Given this list of marker genes ADARB1, PIP4K2C, POMT2, ABAT, HLA-G, RASSF2, MAP2K1, APMAP, JAK1, RAB8B, TENM1, SPTBN1, TMEM248, ANGPTL2, NCALD, TNFRSF25, OMG, EPAS1, SGK1, HTR2B, ADAM23, RAC2, ID3, COTL1, EGR1, CD6, EHD4 (EH domain containing 4), DCLRE1A, CRTAM, HCP5, PLA2G4C, INPP5B, STAT1, IFITM1, IL6R, HGF (NCBI Gene Id 317720), DHRS3, GBP2 (NCBI Gene Id 2634), PDCD4, LPIN2, ICOS, TNF, PTCH1, KLF10, SATB2, RBM38, BACH2, IER2, ZFP36L1, HDAC5, DCHS1, NR4A3 (nuclear receptor subfamily 4 group A member 3), VAV1, CLEC2D (C-type lectin domain family 2 member D), TNFRSF1B, SARAF, SIRPG, VCL, SGPL1, QPCT, AGT, CAMSAP2, EFNA4 (ephrin A4), IL16, ULK2, PIK3IP1, COL6A3, SPINK2, NELL2, OAS2, SCML1 (Scm polycomb group protein like 1), MAN1C1, ARL6IP5, SATB1, BNIP3, PHLPP2, GCH1, LINC00623, DOK2, MSN, TMEM204, SLC7A7, PDE4B, CD200, GVINP1, ATF7IP2, CBLB, HLA-C, STX17 (NCBI Gene Id 9485), TRAF3IP3, PDGFA, TRAF5, ADGB, MAPK13, RAB29, CTSL, CD27, RGS12, SH2B3 (NCBI Gene Id 10019), ABCB1, TNFSF10, GRB10, ST3GAL5, GIMAP4, SPON1, NLRP1, APCS, PTK2, CCR7, ZNF589, IL4R, PTPN12, DENND2D (NCBI Gene Id 79961), ARHGEF6, SP110, BAG3, TATDN2, KDM4B, NEDD9, FUCA1, GALNT11, LEPROTL1 (NCBI Gene Id 23484), IFI44L, CBFB, GPR183, TOR1B, CACNA2D2, ITPKB, HLA-B, HIVEP2, ITGB2, CEACAM1, LRRN3, ST6GAL1, SPOCK2, MYH13, LBP, CRELD2, LBH, GIMAP5, SH2D3A, HNRNPH1, LRRC2, PRMT2, PPP2R5A, GOLGA8B, OSBPL8, SEMA4C, BIRC3, VOPP1, TRIM38, GOLGA8A, MID2, ABLIM1, LTB, TOR1AIP1, IL6ST, LYPD3, S1PR1, ENC1, DBH, KCNH2, IL2RB, ACVR2A, IFI44, CD53, SKAP1, PLEKHA1, G3BP2, IL27RA, SYNE1, LCP2 (lymphocyte cytosolic protein 2), SLAMF1, CAMK1D, RASGRP2, LPXN, SERPINB9 (NCBI Gene Id 5272), FOXO1, GPR65, PRKCH, FCMR, SMAD7, TPK1, SMPD1, ERMP1, REEP5, RETREG1 (reticulophagy regulator 1), TSC22D3, FAM184A, TNFAIP3 (NCBI Gene Id 7128), LY9, ACTN1 (actinin alpha 1), SLC13A4, ZNF516, PIM2, PTPRC, EEIG1, EVI2A, FCGBP, here is a description of the gene set: Genes down-regulated in comparison of intrathymic T progenitor cells (ITTP) versus CD4 thymocytes. Human Gene Set: GSE1460_INTRATHYMIC_T_PROGENITOR_VS_CD4_THYMOCYTE_DN from publication Lee MS, Hanspers K, Barker CS, Korn AP, McCune JM (PMID 15210650) studied in species Homo sapiens Subpopulations of human fetal thymocyte and circulating naïve T cells were obtained through FACS sorting, including CD3-CD4+CD8- intrathymic T progenitor cells (ITTP), CD3intCD4+CD8+ \double positive\ thymocytes (DP), CD3highCD4+CD8- \single positive\ thymocytes (SP4), CD3+CD4+CD8-CD45RA+CD62L+ naive T cells from cord blood (CB4+), and CD3+CD4+CD8-CD45RA+CD62L+ naive T cells from adult blood (AB4+).